The following is a description of a gene set: from publication Zeller KI, Jegga AG, Aronow BJ, O'Donnell KA, Dang CV (PMID 14519204) Genes up-regulated by MYC and whose promoters are bound by MYC, according to MYC Target Gene Database. Human Gene Set: DANG_MYC_TARGETS_UP studied in species Homo sapiens We report a database of genes responsive to the Myc oncogenic transcription factor. The database Myc Target Gene prioritizes candidate target genes according to experimental evidence and clusters responsive genes into functional groups. We coupled the prioritization of target genes with phylogenetic sequence comparisons to predict c-Myc target binding sites, which are in turn validated by chromatin immunoprecipitation assays. This database is essential for the understanding of the genetic regulatory networks underlying the genesis of cancers., and this is the list of marker genes: PAX3, CTSC, RPL27A, NBN, PSMB1, GNL3, NME1, LDHA, CBX3, LTA4H, TXN, CKS2, PYCR1, PPIA, DDX10, CSTB, NAP1L1, DBI, SNRPD3, MAT2A, YBX3, HSPE1, CCKBR, HSPA4, PRPS2, SLC25A3, TYMS, RPL27, FXN, ID2, PPAT, TP53, CDC25C, MRTO4, E2F3, HNRNPA1, EIF4A1, TFRC, RPL13, NRAS, RPS17, E2F1, DKC1, CCNB1, DDX5, RPS5, RPL19, RPL22, GAPDH, MGST1 (microsomal glutathione S-transferase 1), H2AZ1, TOP1, RPS16, EXOSC8, SRM (spermidine synthase), SRSF2, RCC1, CCT5, HSPA8, SMN1 (survival of motor neuron 1, telomeric), PREP, CDK4, RPS20, RPL32, AIMP2, EIF4E, RFC2 (NCBI Gene Id 5982), PSMG1, DDX18, NUP155, UXT, UCHL1, TK1, HSP90AA2P, MTHFD1, CCND2, MIR155HG, PINK1, SHMT1, PRDX3, ENO1, RPL9, SRSF7, RPS6KA2, RPL3, CEBPZ (CCAAT enhancer binding protein zeta), HNRNPA2B1, HSPA9, APEX1, CAD, SURF6, FOSL1, EIF3C, TERT, PTMA, CDC25A, IRF9 (NCBI Gene Id 10379), EIF4B, EIF2S1, METTL1, HSPD1, EMP1, HMGA1, AKAP1, RIOX2, PPID, POLD2, MSH2, NPM1, DPY30, PA2G4, SRSF1, RPL5, UBE2C, PHB1, RPS19, RPL26, BCAT1, MYCT1, RPS13, SNRPB, SLC39A6 (NCBI Gene Id 25800), IMPA2, PCNA, FASN, ODC1, BAX, NME2, RPL10, NCL